Given this list of marker genes ADK, THRA, DCHS1, PA2G4, ATP11B, ZNF688, MGAT4A, DPY19L1, SLC66A2 (NCBI Gene Id 80148), SORT1, ACY1, GALR2, GSE1, TSPOAP1, XPO6, KLRC3, PROCR, SOBP, PWP1, OFD1, NAA10, ITM2C, SOX12, ARID3B, LAT2, CCL5, CLEC11A, ACACA, AQP3, SLC41A3, METRN, MT4, PLP2 (proteolipid protein 2), ALDH18A1, WDR19, HSP90B1, ZFTA, ITGB7, NIPAL3, BATF3, TARS2, KLRB1, SCPEP1, MLLT11, FNDC11, RBM28, MED24, HMGCR, PGD, ANKRD17, DYSF, PCNT, NCALD, EPHA1, TSPAN32, MCCC2, SNRK, TBC1D1, P4HTM, ZNF408, CD8B (NCBI Gene Id 926), CCDC28A, FSTL1, SEMA3E, YPEL1, IGHM, RNF216, BCL6, HPS6, LDLRAP1, RABAC1, TRIM21, KIFAP3, NDUFA3, TDRD12, PPP1R14B, PITX2, PHB2, RPL21, ARHGEF4, LPCAT4, ULK2, SIPA1L1, ANXA11, CCDC69, EGLN1, NHERF1, SENP6, PRF1, CABIN1, PDPN, CRYGD, HINT1, SPOCK2 (SPARC (osteonectin), cwcv and kazal like domains proteoglycan 2), THOC5, B4GALT3, IQGAP2, TMEM100, FKBP11, TUBB2A, TRPV2, ADGRE5, MED17, S100B, ARHGEF7, RABGAP1, GTDC1, EEF2, TWF2, ITPK1, PCNX1, OSTF1, EFEMP2, ELOVL4, IL7R, TACC1, COQ2, H2AC15, IGFLR1, PRDX6, GYS1, NAGLU, RPL6, LBH, MCF2L, IKBKE, ZFAND3 (NCBI Gene Id 60685), RPL18, CLIC3, TPST2, MAGED1, NPEPPS, IRS1, MYC, CYP4F3 (NCBI Gene Id 89256), TRAK1, KRTAP2-4, ATP1A3, SPON2, EPCIP, TARP, HARS2, ERMP1, ZXDB, MYBL1, CDYL, LIN37, PAM16, PHF1, BMAL1, GTF2A1, MAN1C1, WDR6, PPEF2, HSD17B7 (hydroxysteroid 17-beta dehydrogenase 7), RPS7, PRKAA2, PMS2P5, APBB3, DCXR, HAAO, RUNX3, STAG3, HOXD12, PRR7, FBLN2, MAP6D1, TBC1D31, CC2D1A (coiled-coil and C2 domain containing 1A), MAN1A1, HNRNPA1, TMEM41B, AK1, NEFH, TP53, PCSK5, PVRIG, COL11A2, PTPN22, PCSK1N, PRL, EIF4A2, TRAF5, LIME1, RETREG2, SGSM3, ANTKMT, MYO15B, ANKRD6, SLC16A2, FAIM, ECI2, PTPRCAP, KRT81, TMCO6, GDI1, ABHD6, DDX4, ZKSCAN7, SCN5A, here is a description of the gene set: Genes up-regulated in CD8 T lymphocytes: control versus activated by anti-CD3 and anti-CD28. studied in species Homo sapiens from publication Hervas-Stubbs S, Riezu-Boj JI, Gonzalez I, Mancheño U, Dubrot J, Azpilicueta A, Gabari I, Palazon A, Aranguren A, Ruiz J, Prieto J, Larrea E, Melero I (PMID 21108462) Human Gene Set: GSE17301_CTRL_VS_48H_ACD3_ACD28_STIM_CD8_TCELL_UP IFN alpha mediated gene expression pattern. The effect of IFN alpha on human CD8 T cells responding to antigen (signal 1) and costimulatory signals (signal 2) provided by beads coated with anti-CD3 and anti-CD28 mAbs. This analysis examined the effects of IFN alpha on human CD8 T cells responding to antigen (signal 1) and costimulatory signals (signal 2) provided by beads coated with anti-CD3 and anti-CD28 mAbs. Magnetically sorted untouched CD8+CD45R0- T cells from three different donors were unstimulated or stimulated with IFNa2b or with anti-CD3/CD28 Beads alone or along with IFNa2b or IFNa5 for 48 hours. Individual mRNA samples were analyzed using HG-U133A 2.0 array gene chips.